The following is a description of a gene set: species: Mus musculus Mouse Gene Set: GOBP_RESPONSE_TO_INTERLEUKIN_15 Any process that results in a change in state or activity of a cell or an organism (in terms of movement, secretion, enzyme production, gene expression, etc.) as a result of an interleukin-15 stimulus., and this is the list of marker genes: Stat5b, Il15, Cd4 (NCBI Gene Id 212762), Il15ra, Il2rb, Jak3, Stat5a, Il2rg, Plcb1, Stat3 (signal transducer and activator of transcription 3), Jak1